Given this list of marker genes UXT, HNRNPA1L3, RPLP0, RPS25, RPL3, RPL8, CUTA, RPL35A, COX7A2L, CIAO2B, EEF1A1, CNN3, RBP4, ZFAS1, PRDX2, RPS4Y1, HSP90AB1, TRMT112, RPS6, CD63, COMMD6, RSL1D1, ITM2A, PENK, RPS27A, RPL38, RPL36AL, EBPL, HNRNPA1, SUB1, EPB41L4A-AS1, FIS1, LSM7, GDI2, RPS15, EDF1, COA3, ATP5MC1, RPL21 (NCBI Gene Id 6144), PRDX6, FAU, RPL10A, MGP, SMIM26, RPS11 (NCBI Gene Id 6205), RPS14, PPIB, SF3B6, RPL14, HNMT, RPL18A, RPS16, TMEM14C, EEF1D, EIF3H (NCBI Gene Id 8667), TPD52L1, RPL9, UBL5, GSTM3, CCN2, RPS8, RAB13, NDUFB10, NDUFS5, RPL10, PRDX1, RPL32, UQCRH, EIF3I, NPM1 (nucleophosmin 1), PRDX5, PRDX4, EIF3M, PARK7, NME1, RPL5, RPS19, RPS13, RPS29, RPL41, EIF3F, RPS21, RPL6, NDUFA1, ATP5MC2, DDT, ATP6V1F, FABP7, TMEM230, EIF3L, RPL13, RPL26, RPL19 (ribosomal protein L19), FTH1, RPS9, CMTM5, RPS3, LUM, NDUFB4, RPL22, EIF3D, SKP1, TOMM7, SNHG8, EEF1B2, SF3B5, BEX3, RPS12, RPS5, SELENOM, COX7B, KRT10, RPL18, RPS24, FKBP7, S100B, NBDY, DCN (decorin), ATRAID, RPL30, COX5B, UFC1, ATP5ME, PFDN5, RPL36, RPS27, TPT1, NACA, RPL4, RPL22L1, RPS15A, EIF3G (eukaryotic translation initiation factor 3 subunit G), CD99, RPL23A (ribosomal protein L23a), SERF2, RACK1, RPL24, RPL15, CNMD, SEC11A, RPS7, RPS10, RPL17, TMEM256, UQCRB, FTL, ATP5MG, RPS23, UCMA, NDUFB5, H1-2, RSL24D1, UQCR10, C19orf53, RPL39, MYL6B, TMA7, PTRHD1, TMEM258, C12orf57, SEC61B, RPL11, LDHB, SNX3, TSPAN6 (tetraspanin 6), KDELR1, FXYD1, PDGFRL, RPS28, RPS3A, RPS2, ATP5MC3, MIA (NCBI Gene Id 8190), CYTL1, ALKBH7, DLK1, RPS18 (NCBI Gene Id 6222), RPLP1, SNRPD2, ECRG4, SNU13, RPS4X, EIF3E, EIF3K, NSA2, SSR2, RPL23, RPL34, RPL36A, EPYC, NDUFA4, NENF, MT1E, TM4SF1, DDOST, RPL7A, here is a description of the gene set: studied in species Homo sapiens The transformation of benign lesions to malignant tumours is a crucial aspect of understanding chondrosarcomas, which are malignant cartilage tumours that could develop from benign chondroid lesions. However, the process of malignant transformation for chondroid lesions remains poorly understood, and no reliable markers are available to aid clinical decision-making. To address this issue, we conducted a study analysing 11 primary cartilage tumours and controls using single-cell RNA sequencing. By creating a single-cell atlas, we were able to identify the role of endoplasmic reticulum (ER) stress in the malignant transformation of conventional central chondrosarcomas (CCCS). Our research revealed that lower levels of ER stress promote chondrosarcoma growth in a patient-derived xenograft mouse model, while intensive ER stress reduces primary chondrosarcoma cell viability. Furthermore, we discovered that the NF-?B pathway alleviates ER stress-induced apoptosis during chondrosarcoma progression. Our single-cell signatures and large public data support the use of key ER stress regulators, such as DNA Damage Inducible Transcript 3 (DDIT3; also known as CHOP), as malignant markers for overall patient survival. Ultimately, our study highlights the significant role that ER stress plays in the malignant transformation of cartilaginous tumours and provides a valuable resource for future diagnostic markers and therapeutic strategies. Human Gene Set: SU_HO_FOETAL_FEMUR_C0_TRANSITIONING_CELL from publication Su Z, Ho JWK, Yau RCH, Lam YL, Shek TWH, Yeung MCF, Chen H, Oreffo ROC, Cheah KSE, Cheung KSC (PMID 38267611) An intermediate cluster between the RC and the HC clusters, expressing genes RPL5, NPM1, EEFIA1, and EIF3E which are associated with ribosome assembly, rRNA processing, and translation.